The following is a description of a gene set: Genes predicted to be targets of miRBase v22 microRNA mmu_miR_367_5p in miRDB v6.0 with MirTarget v4 prediction scores > 80 (high confidence targets). species: Mus musculus from publication Chen Y, Wang X (PMID 31504780) Mouse Gene Set: MIR_367_5P, and this is the list of marker genes: Wipf1, Nsun7, Hnrnph3, Mapk10, Xylt2, Magi3, Fbxo33, Epb42, Krtap1-4, Macroh2a1, Meis2, Tnik, Maoa, Wdr7 (WD repeat domain 7), Ctps2, Pten, Csrp3, Gna14, Uhrf1, Man1a, Cops2, Ryr3, Stag1, Smarca5, Map10, Dab1, Rhox3f, Mbnl2, Or2ag2b, Rgs7bp, Il22b, Rab3b, Fgd2, Zcchc14, Rsph6a, Nr3c1, Larp4b, Ube2d3, Septin6, Cks2, Fhdc1, Grip1, Plau, Trpa1, Pds5b, Lrrtm3, Tmem161b, Srsf3, Dusp16, Tmod1, Sall1, Jazf1, Gm5820, Slfn9